The following is a description of a gene set: Human Gene Set: HP_DECREASED_SPECIFIC_PNEUMOCOCCAL_ANTIBODY_LEVEL studied in species Homo sapiens The presence of normal overall immunoglobulin levels with deficiency of specific immunoglobulins directed against pneumococci. Decreased specific pneumococcal antibody level, and this is the list of marker genes: CD81, ZAP70, CTPS1, IGHG2 (immunoglobulin heavy constant gamma 2 (G2m marker)), IGKC (immunoglobulin kappa constant), PIK3CD, CBLB, CR2, TNFRSF9